Given this list of marker genes Htr7, Htr2c, Htr1f, Htr4, Htr6, Htr1a (5-hydroxytryptamine (serotonin) receptor 1A), Htr1b, Htr5a, here is a description of the gene set: species: Mus musculus This event has been computationally inferred from an event that has been demonstrated in another species.<p>The inference is based on the homology mapping from PANTHER. Briefly, reactions for which all involved PhysicalEntities (in input, output and catalyst) have a mapped orthologue/paralogue (for complexes at least 75% of components must have a mapping) are inferred to the other species. Reactome Pathway: Serotonin receptors part of: Amine ligand-binding receptors electronically inferred by orthology from the curated human pathway